The following is a description of a gene set: species: Mus musculus The chemical reactions and pathways involving a deoxyribonucleoside triphosphate, a compound consisting of a nucleobase linked to a deoxyribose sugar esterified with triphosphate on the sugar. Mouse Gene Set: GOBP_DEOXYRIBONUCLEOSIDE_TRIPHOSPHATE_METABOLIC_PROCESS, and this is the list of marker genes: Nudt15, Nudt16, Pnp, Ak3, Rrm2b, Adk, Oga, Ada, Dguok, Itpa, Guk1, Ak2, Samhd1 (NCBI Gene Id 56045)